The following is a description of a gene set: Mouse Gene Set: GOBP_RESPONSE_TO_GONADOTROPIN studied in species Mus musculus Any process that results in a change in state or activity of a cell or an organism (in terms of movement, secretion, enzyme production, gene expression, etc.) as a result of a gonadotropin stimulus., and this is the list of marker genes: Epha3, Inhbb, Gclc, Asns, Epha5, Gata6, Star, Cyp1b1, Epha8, Pax8, Gclm, Ppargc1a, Itga3, Ccna2, Gata4, Ghsr (NCBI Gene Id 208188), Fshr, Npr2, Pappa, Inhba, Wt1, Akr1c18, Lhcgr, Foxl2, Gata1, Ednra, Gjb2, Pde4d, Mas1, Tgfbr3, Efna5, Ctsl, Edn1, Notch1, Nsmf, Srd5a2